Given this list of marker genes SCN3A, SCN11A, ATAT1, THBS4, TAC1, UCN, SLC6A2, PIRT, PRKCG, CAPN2, P2RX2, SCN9A, TSPO, NMUR2, VWA1, CRH, GRIA1, GCH1 (GTP cyclohydrolase 1), COL6A1, MTOR, THBS1 (thrombospondin 1), TRPV1, TRPA1, LPAR5, P2RX4, RELN, TACR1, DBH, ADAM11, P2RX3, RET, AKT1, NTRK1, EDNRB, here is a description of the gene set: species: Homo sapiens Any process that results in a change in state or activity of a cell or an organism (in terms of movement, secretion, enzyme production, gene expression, etc.) as a result of a pain stimulus. Pain stimuli cause activation of nociceptors, peripheral receptors for pain, include receptors which are sensitive to painful mechanical stimuli, extreme heat or cold, and chemical stimuli. Human Gene Set: GOBP_RESPONSE_TO_PAIN